Given this list of marker genes CAND1, TPI1P2, PEX26, SEC24C, MRPL42, FAM81A, TBX3, STIP1 (NCBI Gene Id 10963), SCRN3, EPM2AIP1, SEMA3C, POLR3GL, WDR55, ANKRA2, ORC6, ANAPC5, RPL30P11, NEAT1, MAT2B, ABHD2, BANP, CERNA3, RNU6-2, GLYCTK, NET1, TNRC18, CDC40 (cell division cycle 40), SNORD95, DDX21, KCTD10, NAA35, ARHGAP1, GOLPH3, C12orf57, DKC1, OAS3, NGDN, TXNL4B, TTC32, RNVU1-21 (NCBI Gene Id 106480190), TMEM115, POU2F1-DT, ITK, FEN1, C5orf52, TACO1, CARD8, NPM1, LARS1, RNY1P15, SYMPK, NOL8, ZFPL1, PDK4-AS1, ST7, FAM161A, ARHGAP32, SRP14-DT (NCBI Gene Id 100131089), NFKBIL1, RSL24D1, POMP, UBE2D3, YARS2, ZNF460-AS1, PAFAH2, CDCA5, STK4, MRPL13, ITPRID2, H4C8, RPS27A, RTEL1-TNFRSF6B, SLC38A2, ZMIZ2, LINC02026, NDUFA2, MPP7-DT, ARRDC3, ARL14, ESYT1, H2AC11, TINF2, LRP6, TAF7, SMIM15, SRP54, PEX11A, DTWD1, HNRNPA1, MCM5, TEX9, LINS1, MGST3, BMPR1B-DT, EPS8, ESPL1, ACTA2, TAF6L, KRT8, SRP54-AS1, PSMA3, LINC01089, PRMT5-AS1, ANXA2R-OT1, RNF44, CAGE1, PMS2P3, MEPCE, HMBOX1, MALAT1, MMS22L, RNU5D-1, FADS2, ING4, MYO1E, AP1G1, ORMDL2, CDK8, MRPS22, TENT5A, IDH1, CDKL3, TRIM24, PHF5A, HMG20A, ALG14, ZBTB4, YAE1, CALM2, STRAP, WDR5B-DT, LINC01635, RNU5E-6P, GPRC5A, SNORA73A, IL23A, LARP4, TMEM94, SLMAP, ZC3H15, KDELR1, LSM4, PIGL, ZNF408, MTBP, GON4L, ANKRD34A, ZSCAN2-AS1, PSMD3, ITFG2 (integrin alpha FG-GAP repeat containing 2), SMCHD1, PAPOLA, BTF3L4, POP4, SART3, RSRP1, HAUS2, DGLUCY, RNU5F-1, TDP1, MUC13, NPRL2, ENSG00000257545, COPS4, GARS1-DT, RNU2-2P, SCAMP1, WDR82, LINC02068, SECISBP2, SLC16A10, PLAC8, RPAIN, FASTKD1, PEX19, CTDSPL2, MED28, KIF20A, INTS2, AAAS, MMACHC, SRP14, CIDECP1, WDR46, ERLIN1, RETREG2, NOP16, CSTF3-DT, ITGB3BP, FOXA3, CCT2, GOLPH3-DT, GTF3C2, MIR4512, S100A10, ZFYVE1, CRADD, PRPF40B, LPCAT3, TEFM, METTL6, HOXA13, SLC35D1, ATP10B, SNORD118, H4C16, KGD4, CENPP, UBE2M, RANBP3, GABPB1-AS1, RNU5B-1, CBX3, COA6, SLC25A44, CARD8-AS1, TMOD3, VPS33A, EPB41L2, TPRKB, NUP42, VPS18, HSD17B12, PIGS, SMARCE1, WDR74, RNU5A-1, EGR1, HYCC2 (NCBI Gene Id 285172), INTS9, MCRS1, PCBP1-AS1, SNRPE, XPOT, ANKRD17, ENSG00000257184, RN7SL1, RFC2, MED7, CDC20, OSGEPL1 (O-sialoglycoprotein endopeptidase like 1), SRRT, TBC1D17, PHLDA1-AS1, RPL21, LINC02499, HAVCR2, UBC, MIR6076, MIR3912, PARAIL, MYO10, SIRT4 (NCBI Gene Id 23409), ZCWPW1, LINC02320 (long intergenic non-protein coding RNA 2320), BUB3 (BUB3 mitotic checkpoint protein), TP53BP1, ENKUR, ADAP2, MIR4754, CCDC163, TAX1BP1-AS1, WDR5B, GOPC, CLDN4, UPK2, EIF3D, DHX38, PPP2R3B, SEC24A, UQCC1, SETD5, PIDD1, IFT56, ZFAND2B, TTC32-DT, MSX2, COX7C, HMBS, TNPO3, TMEM242-DT, TRABD2A, SNRNP27, PRDX6, ICE2, FAM227B (NCBI Gene Id 196951), PEAK1, MRPL24, CNOT2, SERP1, MCU (mitochondrial calcium uniporter), H1-2, POU2F1, TTC28-AS1, RPL31, RNU4-2, CCDC91, LUC7L2, PSMC3, RAD51AP2, UTRN, BAZ2A, COA6-AS1, PTTG1 (NCBI Gene Id 9232), TIMELESS, CBX5, RPLP2, TUFT1, PDE12, CEP95, DNAJC27, WASF1, HOXA9, LMAN2, HILPDA, CIB1, SUMF2, SLC38A2-AS1, SRSF5, CLCN3, GABPB1, LRRC61, PAN2, EAF1, NFKBIZ, FBF1, TTI2, TLN2, KIF14, H2BC11, ZMAT2, DNAJB12, NUDCD3, EIF4B, COQ7-DT, SLC30A6-DT, HOXA-AS2, MPZL3, LAPTM4A-DT, ZNF770, RACK1, C2CD2L, AASDH, RIOK1, PPHLN1, ENSG00000271860, SLTM, GHET1, ERBB3, SEC24D, HNRNPA2B1, GTF2H1, TSC22D2, RPAP1, SARNP, GTF3C4 (NCBI Gene Id 9329), POLG-DT, FAM3D, CCDC124, TXNDC12, EIF2A, KIAA1217, ZC3H10, MAGOHB, NBPF1, RNU7-1, TRMO, MZF1-AS1, PEX11G (NCBI Gene Id 92960), FRK, MGST1, SNORD13, TP53, STRIP1, STMN3, COG3, H2AC6, SEMA4B, SYT11, MIR5087, OSGEPL1-AS1, ITFG2-AS1, POLD2, GTF3C2-AS2, RAB11A, LINC01730, ATP6V1G2-DDX39B, FBXO38, PLS1, EFCAB11, MYG1, CNOT1, ACO2, CAPZA2 (NCBI Gene Id 830), NADK2 (NAD kinase 2, mitochondrial), DEXI, MLH1, CYB561D2, MIR3913-1, PPIB, DDX47, RPS14, UBE3B, DDX5, AGR2, APOLD1, CIPC, PFDN6, TMEM161B-DT, RNU5E-1, LRRC28, MED28-DT, PRKAR2A-AS1, ELF1, RBM23, KAZALD1, NDUFB3, NUP88, FANCD2, NTPCR, BRD8, CTDSPL2-DT, DPP8, MANSC1, LINC02901, SUGT1-DT (NCBI Gene Id 116435302), PAPOLA-DT, LINC02889, SNX19, FBXL19 (NCBI Gene Id 54620), EMG1, PHB2, ECM2, CNPPD1, RSRC2, RPS5, PTGES3, ACAA1, SUGT1, TMEM259, ENTPD1-AS1, STK4-DT, LAPTM4A, COMMD6, TCERG1, ANKHD1-EIF4EBP3, WARS1, APC, POLR2A, PREPL (prolyl endopeptidase like), KNTC1, PIKFYVE, FER, GAPDH, PDCD6IP, UTP15, RNVU1-2, KAT14, SCAMP1-AS1, CDC42BPA, PHF14, CLHC1, ANKHD1-DT, RPS20, GAPDH-DT, COPS5, UBR1, WDR93, RANBP3-DT, SLU7, ATF7IP, ZNF79, GRPEL2, RBM8A, TMEM242 (transmembrane protein 242), MRPL34, STAMBPL1, RNY1, ZNF335, BMPR1B, DPAGT1, SLC30A6, VCPIP1, MARVELD2, RNY4, ANKHD1, FANCI (FA complementation group I), ATP6V1G2, CDCA3, SERBP1 (SERPINE1 mRNA binding protein 1), TRIM59 (NCBI Gene Id 353185), RTEL1, ANAPC10, ASB7, WRAP53 (WD repeat containing antisense to TP53), ZNF460, AKT1S1, RIPK2, PCBP1 (poly(rC) binding protein 1), COQ7 (NCBI Gene Id 51672), LIX1L-AS1, FDPS, SNORD54, POLG, TFAP2A, RCHY1 (NCBI Gene Id 29027), here is a description of the gene set: Human Gene Set: CIC_TARGET_GENES from publication Yevshin I, Sharipov R, Kolmykov S, Kondrakhin Y, Kolpakov F (PMID 30445619) species: Homo sapiens Genes containing one or more binding sites for (CIC) in their promoter regions (TSS -1000,+100 bp) as identified by GTRD version 20.06 ChIP-seq harmonization.